Given this list of marker genes Nsfl1c, Bnip2, Nubp2, Tmem201, Nde1, Numa1, Npm1, Cep250, Dlgap5, Emd, Aurka, Ubxn2b, Kifc1, Tbccd1, Abraxas2, Misp, Spout1, Rock2, here is a description of the gene set: A centrosome from which one pole of a mitotic or meiotic spindle is organized. species: Mus musculus Mouse Gene Set: GOCC_SPINDLE_POLE_CENTROSOME